The following is a description of a gene set: from publication Gross C, Dubois-Pot H, Wasylyk B (PMID 17704799) species: Mus musculus The ternary complex factor Net/Elk3 is downregulated in hypoxia and participates in the induction by hypoxia of several genes, including c-fos, vascular endothelial growth factor and egr-1. However, the global role of Net in hypoxia remains to be elucidated. We have identified, in a large-scale analysis of RNA expression using microarrays, more than genes that are regulated by Net in hypoxia. In order to gain insights into the role of Net in hypoxia, we have analysed in parallel the genes regulated by HIF-1alpha, the classical factor involved in the response to hypoxia. We identified about genes that are regulated by HIF-1alpha in hypoxia. Surprisingly, when we compare the genes induced by hypoxia that require either Net or HIF-1alpha, the majority are the same (75%), suggesting that the functions of both factors are closely linked. Interestingly, in hypoxia, Net regulates the expression of several genes known to control HIF-1alpha stability, including PHD2, PHD3 and Siah2, suggesting that Net regulates the stability of HIF-1alpha. We found that inhibition of Net by RNAi leads to decreased HIF-1alpha expression at the protein level in hypoxia. These results indicate that Net participates in the transcriptional response to hypoxia by regulation of HIF-1alpha protein stability. Genes down-regulated in SEND cells (skin endothelium) at normal oxygen (normoxia) conditions after knockdown of ELK3 by RNAi. Mouse Gene Set: GROSS_ELK3_TARGETS_DN, and this is the list of marker genes: Iigp1, Cxcl2, Fam162a, Gbe1 (NCBI Gene Id 74185), Hoxb9, Upp1, Cth, Bnip3, Slpi (NCBI Gene Id 20568), Oas3, Ptgs2, Bhlhe40 (NCBI Gene Id 20893), Ramp3, Ero1a, Il6, Vldlr, Adamts1, Hax1, Cope, Ifi44, Ifi202b, Cnot7, Pdk1 (pyruvate dehydrogenase kinase, isoenzyme 1), Rsad2, Socs3 (suppressor of cytokine signaling 3), Acox2, Helt, Pgm1, Maff, Prkg2, Plek, Adamts4, Csrnp1, Ak4, Fth1